The following is a description of a gene set: studied in species Homo sapiens Human Gene Set: HP_CAROTID_ARTERY_DILATATION Carotid artery dilatation A dilatation (balooning or bulging out of the vessel wall) of a carotid artery., and this is the list of marker genes: MYH11, ACTA2, SMAD4, DCDC2, TMEM67, TGFB2, TGFBR1, MFAP5, MYLK, STAT1, SMAD3, TGFBR2, LOX, FOXE3, PRKG1, TGFB3, IPO8, SMAD2, FBN1 (fibrillin 1), ELN, HEY2, THSD4, MAT2A